Given this list of marker genes RALB, RAP1A, CRK, CRKL, MAPK11, RIT2, RAPGEF1, SOS1, FRS2, MAP2K1, KIDINS220, NTRK1, RALA, NGF, MAPKAPK3, MAPK14, MAPKAPK2, RIT1, MAPK1, GRB2, MAPK13, MAP2K2, SRC, SHC2, BRAF, RALGDS (ral guanine nucleotide dissociation stimulator), SHC3, NRAS, YWHAB, HRAS, MAPK12, MAPK3, KRAS, SHC1, here is a description of the gene set: Signalling to ERKs Human Gene Set: REACTOME_SIGNALLING_TO_ERKS species: Homo sapiens